The following is a description of a gene set: Low 1-minute APGAR score studied in species Homo sapiens Human Gene Set: HP_LOW_1_MINUTE_APGAR_SCORE, and this is the list of marker genes: MAGEL2, PWAR1, MCTP2, SNORD116-1, PRPS1, SNORD115-1, USP9X, PWRN1, MKRN3, NPAP1, MTM1, FGFR3, HERC2